The following is a description of a gene set: A process required for sperm to reach fertilization competence. Sperm undergo an incompletely understood series of morphological and molecular maturational processes, termed capacitation, involving, among other processes, protein tyrosine phosphorylation and increased intracellular calcium. species: Homo sapiens Human Gene Set: GOBP_SPERM_CAPACITATION, and this is the list of marker genes: CATSPER2, SEMG2, ROPN1, DEFB1, ABHD2, SLC26A6 (NCBI Gene Id 65010), SLC26A3, CATSPERD, DLD, ELSPBP1 (epididymal sperm binding protein 1), SLC22A14, TCP11X1, CABYR, CATSPERE, PCSK4, ROPN1B, CFTR, CATSPER4 (NCBI Gene Id 378807), TCP11X2, TMPRSS12, CATSPER3, SPINK1, CATSPERZ, ROPN1L, BSPH1, EFCAB9, IQCF1, CCR6, TCP11, C2CD6, PRKACA, ADAM7, SEMG1, PAEP